Given this list of marker genes CTNNB1, C2orf76, SLC7A6, ELL, EIF1B, TLE4, XIAP, COMMD3-BMI1, LYSMD3, SP3, FABP2, CREBZF, WASF3, SMARCAD1, BNC2, DNAJB9, KANSL1L, ADIPOQ, SYT1, NFIX, EOGT, CCND2, AAK1, RAB27B, APPBP2, TBC1D1, SLC4A4, DDX3X, PDIK1L, FOXA2, DENND1B, XPO6, TRAF6, EHBP1, GPD2, ZBTB6, GATA3, ST6GAL2, FOXP1, UGT8 (UDP glycosyltransferase 8), GLCE, EPB41L2, FUT9, MYSM1 (Myb like, SWIRM and MPN domains 1), ERAP1, SACS, KLF12 (KLF transcription factor 12), SNAP91, ATXN1, AFF2, SLC11A2, COL15A1, FOXK1, E2F3, CHRM2, KIF3A, ATG14, RHBDL3, PDHA1, CDC42, DCP1A, SEMA6A, TSEN2, CTDSP2, PRDM2, SLC6A11, MBNL2, HNRNPA0, RALGDS, CXADR, ZMYM3 (zinc finger MYM-type containing 3), USP37, TLCD5, PITPNC1, AFF4, ARHGEF7 (NCBI Gene Id 8874), HOXD10, EDEM3, RBMS3, NAV1, KHDC4, PARP11, TRPC5OS, MED21, HOOK3, ADGRB3, RAB22A, SPOCK1, CHSY3, AKAP11, ZNF804A, PRKAR2A, RNF8, CASK, SKIDA1, SYDE2, ANKRD22, AMOTL1, SATB1, TMPRSS13, RREB1, ZNRF3, CD9, RTL5, PSD3, PLGLB2, BRWD3, KMT5B, FHIP2A, SOS1, FAM3B, ZFTA, PRR14L, PPP6R2, GNAQ, SUCO, FAXC, TTC6, TPM3, GNA13, CPEB3, UFSP2, ROBO2, ARK2N, CDK17, CELF1, CEP41, ZNF292, CSMD3, GNPTAB, MSL2, GABRA4, GRIA3, ZDHHC17, SYPL1, ATL2, PRKD3, OPA1, P4HA1, LIN7C, ACYP2, SLC7A1 (NCBI Gene Id 6541), SETD5, MMS22L, ARHGAP5, CNTN4, SLC35G1, TXLNA, COL24A1, PLAC8, JOSD1, POLR2K, ARHGEF2, TRIM7, GPAT3, CHCHD3, UBN2, ZNF609, C2orf88, HNRNPA2B1, CRIM1, RANBP9, AK9, NBPF11, GTF2I, NFIA, ZNF783, LMO4, LAMP2, PRTG, SLC44A5, NXPE3, AP1G1, ATP6V1A, GOLGA6L1, DHX36, DCX, BCL10, ZFHX3, ST8SIA4, ERLEC1, HBEGF (heparin binding EGF like growth factor), C18orf63, GNB4, GPATCH11, SH2B1, NAV2, SGTB, SARAF, NRG4, MAST4, SORBS2, SRRM1, IGFL4, MAK (male germ cell associated kinase), CUX2, SUCNR1, ZNF678, SPHKAP, SERPINE2, WDR45B, KCNMA1, DFFB, CDC6, NUP153 (NCBI Gene Id 9972), PBRM1, CFL2, CSRNP3, PTBP3, KRT37, KCND2, MRPL2, NCKAP5L, NUFIP2, SLC39A6, U2AF2, APPL1, NBPF12, ITGAV, ARFGEF2, NCAM2, ZDHHC13, EYA3, PKN2, ZC3H11A, RBBP4, MBNL3 (NCBI Gene Id 55796), ADD3, REPS2, ZNF670, LRP1B, EGR4, EXOC6, SLC30A5, GATAD2A, CLASP2, RNF180, SHISA2, CUL3, LONRF2, USP3, ZNF454 (zinc finger protein 454), MYEF2, SLC10A7, CLCF1, ING3, PREX2 (NCBI Gene Id 80243), UBE2W, LRRC51, CCL20, CARNMT1, DRAM2, DPPA4, PLGLB1, ADGRL3, ELOVL2, CHN2, CCDC85A, TMX4, ARL5A, TMEM179B, SPATA6L, PPM1A, EPAS1, HMGN2, PARM1, LCOR, ERMP1, HP1BP3, PHTF2, COL4A4, DACH1, SPPL3, ZHX2, PCP4, YTHDF3, ABCB7, CXXC5, MTMR9, ZBTB34, CFI, CNOT6, POU2F1, MAP4K3, CELF4, NDUFC2, CHORDC1, MID2, SMAD5, TCEA1, TULP4, ARIH1, NUDT4, UBE2E2, SLC5A3, NBPF1, RBM25, ARHGAP29, IRF4, RPRD1A (regulation of nuclear pre-mRNA domain containing 1A), VGLL4, TRMT11, FBXO6, AEN, ARHGAP12, PCDH20, NR4A2, DNAJB6, DPYSL2, KLF10, MRO, PNMA2, RDX, MIER3, ELF2, IFT56, ARID4B, PDE1C, U2SURP, BCL2L15, EPM2A, HIGD1A, HEG1, CDYL2, PRKAA1, PUM1, SEPTIN7, CCDC150, KLHDC2, FDXACB1 (NCBI Gene Id 91893), IKZF2, AASS, HTR1B, MINAR1, GDA, KDM7A, SLC22A5, ROBO1, RBMXL1, VPS13A, BBX, MAGEB4, PCDH9, PRKACB (NCBI Gene Id 5567), LZTFL1, STK39, SMIM12, ISCU, TMEM38B, NBPF14, ATP7A, ZFR, SSB, LGR4 (NCBI Gene Id 55366), SOX9, LNPEP, MAPKAPK2, NEDD9, GNAL, BRINP1, SLC24A2, PBX2, CWC27, COL16A1, FBXW11, LRRC25, RFX7, SH2D1B, KCTD12, EIF5A2, ESCO2, ERI1, RELCH (NCBI Gene Id 57614), FCHSD2, UFM1, RBM44, MAP3K4, SLC25A32 (NCBI Gene Id 81034), PCDH19, GPBP1, MPPED2, PCDH10, SRSF1, TFAP4, CEP120, PUS10, RAB30, RAPGEF6, CDK6, TMEM68, GRM3 (NCBI Gene Id 2913), N4BP2L2, NBPF9, TRIM6, MLLT3, RUNX2, CACNA2D1, SLC25A36, SCAI, SNX30, KSR2, OR11A1, DESI2, NBPF20, OGFRL1, TET2, CMIP, SORBS1, COMMD2, STRBP (NCBI Gene Id 55342), ALG10B, SEMA4C, RBM46, GNG4, UHMK1, TCAIM, ZNF649, SOX6, OR7A5, GPRASP2, CIRBP, TRA2A, NAMPT, PRRX1, MEF2A (myocyte enhancer factor 2A), ARPIN, HAVCR2, FOXF2, NBPF8, C16orf46, GLTP, RASA1 (NCBI Gene Id 5921), NBPF3, HCFC1, EPB41L5, MBTD1 (mbt domain containing 1), GNAI3, CBL, AP3M1, FAM9A, LMO7, EPPK1, TP53RK, ETNK1, PIK3CB, AK2, DGKB (NCBI Gene Id 1607), ANKRD10, VPS50, SLC39A8, NBPF15, MTTP, FGF13, CELF2 (NCBI Gene Id 10659), CRIPT, PHC3, EI24, BCKDHB, RETREG2, PPP4R4, HERC5, KREMEN1, N4BP2, LRRN1, PAN2, MORC1 (NCBI Gene Id 27136, MORC family CW-type zinc finger 1), KAT6A, CDC42SE2, CAMKK2, SP100, MAN2A1, ARHGAP21, YAP1, DMRTC2, WTAP, TRUB1 (TruB pseudouridine synthase family member 1), HNRNPLL, GMEB1, SCN1A, FPGT, ZNF236, EGLN3, CASP3, CENPH, CASD1, SIAH1, NKX2-1, SYT4 (NCBI Gene Id 6860), SBNO1, SLC19A2 (NCBI Gene Id 7826), VDAC1, RNFT2, TMEM192, SPECC1, ELOVL7, GHR, ZNF484, KHDRBS1, LRP12, TESMIN, TOX3, TASOR, PLCXD3, MCTS1, ST7, TBL1XR1, ETV5, PHACTR2, IER5, CMTR2, XRN1, HIVEP1, FKBP6, FLT1, PCDH11X, FXN, RNF44, NTRK2, GPATCH2L, BTRC, RCOR1, ZNF384, TOR1AIP2, ST7L, NCOA6, SLC4A5, FSD1L, ALOX15, ADSS2, PRICKLE3, TOR3A, ZNF780A, TRIP12, PBLD, SLC12A6, MEF2D, EPPIN-WFDC6, DHX8, PMP2, CAAP1, BET1, ALDH6A1, RABL6, SAMD8, ARRDC3, UNC5C, CCNT2, here is a description of the gene set: species: Homo sapiens from publication Chen Y, Wang X (PMID 31504780) Human Gene Set: MIR3529_3P Genes predicted to be targets of miRBase v22 microRNA hsa-miR-3529-3p in miRDB v6.0 with MirTarget v4 prediction scores > 80 (high confidence targets).